The following is a description of a gene set: Mouse Gene Set: GOBP_PROTEIN_HOMOTRIMERIZATION studied in species Mus musculus The formation of a protein homotrimer, a macromolecular structure consisting of three noncovalently associated identical subunits., and this is the list of marker genes: Sigmar1, Steap4, P2rx3, Itln1, P2rx7, Alox5ap, Slc1a2, Clybl, Mif, Pxdn (peroxidasin), Mbl1, Mlkl, H2-M3, Slc1a5, Scara5, Pnpt1